The following is a description of a gene set: Human Gene Set: DACOSTA_UV_RESPONSE_VIA_ERCC3_DN Genes down-regulated in fibroblasts expressing mutant forms of ERCC3 after UV irradiation. studied in species Homo sapiens from publication da Costa RM, Riou L, Paquola A, Menck CF, Sarasin A (PMID 15608684) Xeroderma pigmentosum (XP) and trichothiodystrophy (TTD) syndromes are characterized by deficiency in nucleotide excision repair pathway, but with distinguished clinical manifestations. While XP patients exhibit a high frequency of skin cancer, TTD patients are not cancer prone. The relation between lack of DNA repair and their clinical manifestations was investigated through analysis of the transcriptional profile of 12,600 transcripts in two isogenic cell lines with different capabilities of DNA repair. These cell lines result from a stable transfection of the XPB-TTD allele into XP complementation group B fibroblasts, from an XP patient who also have clinical abnormalities corresponding to Cockayne's syndrome (CS). The microarray assays performed under normal growth conditions showed the expression of distinct groups of genes in each cell line. The UVC-transcription modulation of these cells revealed the changes in 869 transcripts. Some of these transcripts had similar modulation pattern in both cells, although with eventually different time patterns for induction or repression. However, some different 'UVC signature' for each cell line was also found, that is, transcripts that were specifically UV regulated depending on the DNA repair status of the cell. These results provide a detailed portrait of expression profiles that may potentially unravel the causes of the different phenotypes of XP/CS and TTD patients., and this is the list of marker genes: TOP1, USP24, WNT5A, TSPAN5, STAM, NEDD4, ARHGAP19 (NCBI Gene Id 84986), CLASP2, ACVR1, KAT6B, N4BP2L2, U2SURP, WBP4, APC, CENPC (centromere protein C), TLE4, ZNF148, DLEU2, SPRED2, DDX21, JARID2, GMPS, DOP1B, HOMER1, CHST3, NSMAF, RBMS1, TANK, TIPRL, FBXL7, SEC14L1, RAB3GAP1, PTPN2, RRAS2, OTUD4, DKK1, PPP2R3A, NDC80, AKAP13, SEC24D, SEPTIN9, DEK, KDM4C, BPTF, HNRNPDL, RB1CC1, BICRAL, SLC16A7, CERS6, WASHC4 (WASH complex subunit 4), TDG, COL8A1 (NCBI Gene Id 57086), SRPK2, RBPJ, SHOC2, ANKS1A, CDC16, RBM39, MYO9B, CEMIP (NCBI Gene Id 57214), PUM2, RSBN1, FAT1, TGFBR3, IER3, MDFIC, TOP2A, BAZ1B, SMAD3, UBR2, STARD13, MGLL, ME2, MKLN1, KAZN (NCBI Gene Id 780789), SRSF7, CEP170, HOXB2, SLC11A2, EIF4G3, GTF2F2, MTCL1, SECISBP2L, ADGRG6, SNX13, KIF2A, CSE1L, STK39, TFPI, WDR7, RB1, ZEB1, PHLPP2, APP, ATP11B, OSBPL8, DAPK1, PIKFYVE, SASH1, SUCO, VCL, SSBP2, KIF11, HELZ, CAP2, SNX2, PDS5A, RAB21, ADORA2B, ATAD2B, MYC, HDAC4, CXCL12, VEGFC, NCOR2, CTIF, SFMBT1, CLIP1, MAD1L1, KLC1, ZHX2, MICAL2, UST, ARID4A, ANKLE2 (NCBI Gene Id 23141), NUP98, KIFAP3, CDK17, MELK, TJP2, TIA1, NFYC, XPO6, LSM5, APPBP2 (NCBI Gene Id 10513), NCKAP1, GNAI1 (G protein subunit alpha i1), SCHIP1, BLTP1 (bridge-like lipid transfer protein family member 1), PKN2, ROCK1, XPO1, PPP3CB, HIVEP2, TMEM87A, GCNT1, CCDC6, PDLIM5, TIAM1, ZFYVE9, KDM3B, MECP2, EXT1, YAF2, USP12, DAAM1, SPOP, HAT1, UBE2E1, COL1A2, ST3GAL5, STIL, TRIO, DHX15, CHSY1, SLC27A3, C2CD5, PPP3R1, UBE3A, ZZZ3, ADCY9, ARHGAP11A, DNMBP, TXNRD1, SKIC3, WAPL, MALT1, ARFGEF1, ZEB2, PPP2CA, TRIM37 (tripartite motif containing 37), ZC3H4, ARIH1, MYO1B, MECOM, DNAJB6, MAMLD1, ZBTB18, HERC4 (HECT and RLD domain containing E3 ubiquitin protein ligase 4), ITSN1 (NCBI Gene Id 6453), PRIM2, CASK, CLINT1, KPNA3, ARNT2, AZIN1, NCOA3, WDR43, IBTK, CENPF, NR3C1, AUH, RLF, TNKS, GINS1, OXSR1, DPYD, TRRAP, MTFR1, SERPINE1, PALS2, RNF13, PUM1, SMARCA1, GUSBP14, RBM6, TTC28, DBF4 (NCBI Gene Id 10926), ATXN2, ATP2B1, KIDINS220, RPGR, CLEC16A (C-type lectin domain containing 16A), ADAM17 (ADAM metallopeptidase domain 17), MEIS2, EMC2, TAF15, FBXW11 (F-box and WD repeat domain containing 11), SOCS6, EIF3A, UTP18, EIF4E, MBNL1, PHF14, CNOT2, CCND1, UBR5, MAP2K4, WWTR1, MTX2, DDX17, GCC2, BHLHE40, FNBP1L, MTR, HNRNPH3, CCSER2, C2CD3, SMARCA2, ACAP2, SLC25A12, PKD2, IL1RAP, LMNB1, BICD1, ASXL1, ARHGAP12, SUZ12, VEZF1, PTEN, ATF2, PIK3C2A, KDM3A, CSNK1A1, PARD3, TMEM131L, ZMYND8, HIF1A, MSH3, GOLGA4, WWC1, ARID5B, FLRT2, UBE2D3, AHCTF1, SMAD4, UBXN7, LARP4B, NREP, LHFPL2, NR2F2, PPP2R5E (protein phosphatase 2 regulatory subunit B'epsilon), SACS, RABGAP1L, TCF7L2, BAZ2B, ZNF638, MAP3K14, MARK3, ANKMY2, NPEPPS, GSE1, KLF10, ZNF804A, MAST2, DUSP1 (NCBI Gene Id 1843), ZMYM4, PPP2R2A, NBN, CENPE, SERPINB2, NEK4, CUX1, RAB6A, RABGAP1, GTF2E2, SPAG9, SRSF3, TAB2, MAP1B, DENND2B, CASP8, R3HDM1, PCCA, PODXL, SPART, SAMD4A, FGF5, BARD1, ADGRA3, FTO, TEAD1, CRADD, ACBD3, CREBBP, EPHA4, IL7R, RBMS1P1, ELOVL2 (NCBI Gene Id 54898), ABCC1, PLSCR1, ADNP, VRK1, SPEN, MTIF2, DDX10, FAM169A, CLOCK, ELL2 (elongation factor for RNA polymerase II 2), CDC42BPA, EVI5, MYOF, CDS2, PRKACB, PALM2AKAP2, PPP1R12A, TP53BP2, CLASP1, PKP4, TBL1X, DMXL2, WWP1, CBFB, BAZ1A, BMERB1, DOK5, IGF2BP3, STAU2, SETDB1, CDK8 (cyclin dependent kinase 8), RASA1, ROCK2, GIGYF2, MTAP, EPS15, TRAPPC8, ARAP2, KIF14, TGFBR2, AQR, ABI1, AHDC1, ANKRD17, ABCE1, ARHGAP29, MARCHF7, PBX3, MED13, FGF2, RIN2 (Ras and Rab interactor 2), PICALM, ZFP36L2, SMURF2, DCUN1D4, GARRE1, PLPP3, DLGAP5, WDR37, STK24, PUM3, GNAQ, FERMT2, PMS1, CDC27, UPF2, SMC5, C2CD2, AP3B1, ZBTB11 (zinc finger and BTB domain containing 11), ID1, MN1, TCF12, ATR, RAP1A, HEG1, SPAST, SIK3, GALNT1, UGCG (NCBI Gene Id 7357), OSMR, PAFAH1B1, MSH6, MOK, MTF2, DUSP5, SMARCA5 (NCBI Gene Id 8467), BRCA1, UBE2D2, UVRAG, ATRN, ERC1, MAPK14, STRN3, ZHX3, ZFYVE16 (zinc finger FYVE-type containing 16), HMGXB4, RDX, RAB31, PPM1B, PSME4 (proteasome activator subunit 4), FAM193A, RGL1, XRCC4, SETD2, AGO2, NCK1, ZDHHC17, NPAT, DLG1, GBE1, PHIP, ACSL4, PHF21A, ENC1, DDR2, PCF11, REV3L, BMP2K, WDFY3, UCK2, TUT4 (terminal uridylyl transferase 4), AURKA, MED1, SNX4, PCMT1, IGF2R, ACSL3, TGIF1, AKAP10, E2F3, NUP153, FOXO3, RFTN1, AKAP11, ORC5, DNAJC2, KDM5B, NVL, TRIM33, HMMR, TBC1D31, MACF1, EGFR, FOXD1 (NCBI Gene Id 2297), TAOK3, ROR1, TUBGCP3, DOCK9, ZMYND11, MDN1, MICAL3, BMPR1A, USP7, CHD9, IPO7, CDYL, TMEM131, TLK2, PPP2R5C, PLCE1, PTPN13, PHF8, LDLR, TSC22D2, MOB4, NALF1, SPECC1L, NBAS, POLR2B, AMPH, INPP5F, RAD23B, FOXK2, SHB, TRIM24, AKAP9, DNAJC13, MAPK8, NMT2, NRG1, PEX14, YAP1, DOCK4, TERF1, KIF23, PAIP1, MAN2A1, NFIB, TTK, CSNK2A1, DDX42, SKAP2, RHOBTB3, MBOAT2, STAG1, TRIM2 (tripartite motif containing 2), SOS2, KIN, CDK19, SLC4A7, GTF3C2, CKAP5, SON, SYNE2, CCDC93, PRKCA, PIK3R4, SLC25A13, SEMA5A, HPCAL1, CREB5 (NCBI Gene Id 9586), PARN, TMCC1, MNAT1, FUBP1, PRKCI, KRIT1, SETD3, ATP6V1H, RBPMS, TOGARAM1, USP15, UBE2G1, TRAK1, ANAPC10, MTREX, RBFOX2, COL5A2, BTRC, TNFAIP8, ITPR1, SEC24B, IFRD1, LPAR1, BBX, VPS13A, ZMYM2, NPIPB3, RCOR1, TLE1, CTBP2, PMM2, QKI, ZMIZ1, CAND1, MAPK6, PDS5B, MARCHF6, FARS2, TGFB2, R3HDM2, NEK1, LARP4, KLF7, CDH2, NUMB, ORC2, KIF20B (NCBI Gene Id 9585), RIF1, LRIG1, CD2AP, SCAMP1, TRIP12 (thyroid hormone receptor interactor 12), USP9X, TLK1, GRK5, KLHL20, HIVEP1, TASOR, MITF, MICU2 (NCBI Gene Id 221154), MEF2A, UBL3, SYNJ2, CAV2, NECTIN3, ZZEF1, MRTFA, EFNA5, MTMR3, ANKRD28, DOCK1, IGF1R, CHD1, BLM, THBS2, CCN2, PTK2, THOC2, PTPRA, USP13, CREB3L2, COG5 (component of oligomeric golgi complex 5), MED13L, ATP13A3, SRGAP2, ADARB1 (adenosine deaminase RNA specific B1), FAM171A1, BTAF1, NUP160, SUPT20H, IRS1, CEP135, CRY1, AGFG1, BCAR3, EPS8, SGMS1, MID1, PHF3, UTP20, TAF4, ARB2A, WASF1, LRPPRC, CDK13, SMCHD1, PLOD2, SLK, NT5C2, PTPN1, RUNX1, PTPRK, NRIP1, EFR3A, MGAT5, FXR1, RYBP, CDKN1B, PSD3, TPST1, PTPN9, FYN, DUSP4, PTX3, SLIT2, ATP8B1, ARHGAP35, ATP2B4, BDNF, PTPN4, INHBB, AFF1, HLTF, STAG2, AFAP1 (NCBI Gene Id 60312), PEX3, JUN (Jun proto-oncogene, AP-1 transcription factor subunit), SP3, ZNF292, PAWR, ARHGEF7, RANBP2, SPG11, PIK3C3, PTPRM, PIP5K1A, PPFIA1, SNW1, SPC25, SATB2, SIPA1L1, MPHOSPH9, N4BP1, OPA1, CNOT4, MSH2, PHLPP1, LAMC1, ZC3H14, SEC24A, SOS1, SLC7A1, FOXN3, STK10, SMAD7, GPATCH8, F3, PCNT, SEMA3C, RYK, GJA1, USP34, SLC25A24, E2F5 (NCBI Gene Id 1875), NBPF14, STK3, ZFHX3, CRYBG3, ASAP2, GAPVD1, LARS2, ITGA6, RPS6KA3, MBD2, FRYL (NCBI Gene Id 728298), SOX9, RGS7, PLCB4, ARHGEF10, TRAM2, ZNF451, MAP4K5, DST, WDHD1, RPS6KA2, KDM5A, OGT, FNDC3A, PJA2, MYCBP2, EPHB2, NUP133, SCAF8, PHF20, EHBP1, YY1, TP53BP1, KLHDC10, PRR3, TOPBP1 (DNA topoisomerase II binding protein 1), NFKB1, CYTH1 (NCBI Gene Id 9267), SMC3, LYN, MNT, FUT8, AGAP1, SLC23A2, RAPGEF2 (NCBI Gene Id 9693), SP100, ALCAM, ATP2C1, PRRC2C, DYRK1A, ATXN1, LRRFIP1, NUAK1, DLC1 (DLC1 Rho GTPase activating protein), NCOA2, FLNB (NCBI Gene Id 8413), MAP2K1, ITSN2, PNISR, CCN1, GSK3B, ADAM10, YTHDF3, SLC35A3, NFATC3, MYBL1, PRMT3, VLDLR, TDRD3, SOCS5 (suppressor of cytokine signaling 5), NAMPT, PIBF1, CTCF (NCBI Gene Id 10664), CUL2, FILIP1L, PTPN12, SWAP70, BUB1B, GALK2, CBLB, DICER1, NIPBL, KLF6, VPS13B, TRIM44, CREB1, MYO10, SMAD6, ASCC3, BRCA2, DENND5A, GNE, PPIP5K2, CAMSAP2, KIF5C, APBB2, CENPA, TIPARP, HIRA, IL1R1, CRIM1, ITCH, GLRB, WASF3, LTN1, TRPC1, RNGTT, SETX, RGS20, PLAUR, DMD (dystrophin, NCBI Gene Id 548327), TDRD7, ATRX, STXBP3, PPP2R5A, MIA2, GBF1, ID3, PDE8A, RALA (NCBI Gene Id 5898), SPIDR, CUL1, SLC20A2, PARG, URI1, MAP3K4, NEK7, NCOA1, FCHSD2, FAM168A, PIP4K2A, FOXJ3, USP6, RAD51C, WRN, ABLIM3, CEP350, AVL9, RNF2, ZBTB20, KAT6A, NAV3